Given this list of marker genes PTPN2, ARG1, PPARG, PARP14, NR1H3, OTOP1, DNAJA3, NR1H2, here is a description of the gene set: Any process that decreases the rate, frequency or extent of a response to type II interferon (interferon-gamma). Response to interferon gamma is a change in state or activity of a cell or an organism (in terms of movement, secretion, enzyme production, gene expression, etc.) as a result of an interferon-gamma stimulus. Human Gene Set: GOBP_NEGATIVE_REGULATION_OF_RESPONSE_TO_TYPE_II_INTERFERON studied in species Homo sapiens